Given this list of marker genes SCNN1A, SGK2, FGD3, FLJ40288, ATP5MFP6, LINC02251, RASGRF2, FCRL1, LRRC27 (leucine rich repeat containing 27), MTFR1L, here is a description of the gene set: Human Gene Set: CREBL2_TARGET_GENES studied in species Homo sapiens Genes containing one or more binding sites for (CREBL2) in their promoter regions (TSS -1000,+100 bp) as identified by GTRD version 20.06 ChIP-seq harmonization. from publication Yevshin I, Sharipov R, Kolmykov S, Kondrakhin Y, Kolpakov F (PMID 30445619)